The following is a description of a gene set: Mouse Gene Set: GOBP_REGULATION_OF_INSULIN_RECEPTOR_SIGNALING_PATHWAY Any process that modulates the frequency, rate or extent of insulin receptor signaling. studied in species Mus musculus, and this is the list of marker genes: Ins2, Ffar3, Sesn3, Prkcq, Lep (leptin), Ahsg, Gkap1, Zbtb7b, Rela, Ptpre, Rbx1, Ankrd26, Ctsd, Cul7, Opa1, Irs1 (insulin receptor substrate 1), Zfp592, Ptprj, Nck1, Pid1, Gnai2, Ptpn2, Nr1h4, C1qtnf12, Rarres2, Tns2, Kank1, Sirt1, Prkcd, Sorl1, Ogt, Pip4k2b, Ncl, Rbm4, Tsc2 (TSC complex subunit 2), Adipor1, Pip4k2a, Ncoa5, Nucks1, Snx5, Socs3, Mir494, Igf2, Pip4k2c, Ptpn1 (NCBI Gene Id 19246), Serpina12, Gpr21, Prkcz, Prkaa1, Agt, Il1b, Ptprf, Lonp1, Gsk3b, Nucb2, Ins1, Socs1, Mstn, Osbpl8, Sorbs1, Pak1, Grb10, Blvrb, Src, Prkcb, Vwa2, Mfn2, Erfe, Marcks, Tnf, Prkca, Enpp1, Inppl1, Sik2, Inpp5k, Mir143, Slc27a4, Mzb1, Rps6kb2, Trim72, Rps6kb1, Grb7, Gsk3a, Fut7, Ptpn11, Grb14, Ide, Fbxw8